The following is a description of a gene set: The directed movement of transferrin into, out of or within a cell, or between cells, by means of some agent such as a transporter or pore. Human Gene Set: GOBP_TRANSFERRIN_TRANSPORT studied in species Homo sapiens, and this is the list of marker genes: DNM2, REP15, TFRC, MCOLN1, TFR2 (NCBI Gene Id 7036), LMTK2, RAB11B, CLTC, HFE, ARHGAP1, B2M